The following is a description of a gene set: species: Mus musculus Catalysis of the reaction: beta-D-fructose 1,6-bisphosphate = D-glyceraldehyde 3-phosphate + dihydroxyacetone phosphate. Mouse Gene Set: GOMF_FRUCTOSE_BISPHOSPHATE_ALDOLASE_ACTIVITY, and this is the list of marker genes: Aldoart2, Aldoa, Aldob (aldolase B, fructose-bisphosphate), Aldoart1, Aldoc